Given this list of marker genes RAD51, SMARCA4, SKIL, KIR2DL4, NPRL2, HSF1, VAMP5, DKC1, CNOT2, UCHL1, here is a description of the gene set: Genes down-regulated in multiple myeloma (MM) compared to normal plasma cells from the patient's identical twin. Genetic heterogeneity between individuals confounds the comparison of gene profiling of multiple myeloma (MM) cells versus normal plasma cells (PCs). To overcome this barrier, we compared the gene expression profile of CD138+ MM cells from a patient bone marrow (BM) sample with CD138+ PCs from a genetically identical twin BM sample using microarray profiling. Two hundred and ninety-six genes were up-regulated and genes were down-regulated at least 2-fold in MM cells versus normal twin PCs. Highly expressed genes in MM cells included cell survival pathway genes such as mcl-1, dad-1, caspase 8, and FADD-like apoptosis regulator (FLIP); oncogenes/transcriptional factors such as Jun-D, Xbp-1, calmodulin, Calnexin, and FGFR-3; stress response and ubiquitin/proteasome pathway-related genes and various ribosomal genes reflecting increased metabolic and translational activity. Genes that were down-regulated in MM cells versus healthy twin PCs included RAD51, killer cell immunoglobulin-like receptor protein, and apoptotic protease activating factor. Microarray results were further confirmed by Western blot analyses, immunohistochemistry, fluorescent in situ hybridization (FISH), and functional assays of telomerase activity and bone marrow angiogenesis. This molecular profiling provides potential insights into mechanisms of malignant transformation in MM. For example, FGFR3, xbp-1, and both mcl-1 and dad-1 may mediate transformation, differentiation, and survival, respectively, and may have clinical implications. By identifying genes uniquely altered in MM cells compared with normal PCs in an identical genotypic background, the current study provides the framework to identify novel therapeutic targets. Human Gene Set: MUNSHI_MULTIPLE_MYELOMA_DN from publication Munshi NC, Hideshima T, Carrasco D, Shammas M, Auclair D, Davies F, Mitsiades N, Mitsiades C, Kim RS, Li C, Rajkumar SV, Fonseca R, Bergsagel L, Chauhan D, Anderson KC (PMID 12969976) studied in species Homo sapiens